Given this list of marker genes MRPS22, WWOX, SLC29A3, GPR101, MEN1, MAP3K1, SYCE1, CDKN1A, MSH4, SNRPN, NR5A1, LEPR (NCBI Gene Id 3953), SNORD115-1, BBS1, CDON, TRAF7, PROKR2, DCC, MKRN3, ARL6, BAP1, PRKAR1A, FGF8, NF2, IL17RD, LHB, TAC3, PWAR1, SRY, USP48, GNRHR, BSCL2 (BSCL2 lipid droplet biogenesis associated, seipin), BMP15, TP63, GDF9, STAG3, PSMC3IP, FGF17, CYP17A1, AKT1, SYCP2L, CAV1, SIM1, KPNA7, PCSK1, LHX4, PIK3CA, SPIDR, HAMP, SEMA3A, DUSP6, HARS2, GLI2, WNT4, HFM1, MCM9, AXL, MSH5, MAGEL2, TFR2, AIP, ROBO1, NPAP1, CDKN1B, PWRN1 (NCBI Gene Id 791114), SPRY4, TKT, OCA2, MSTO1, TERT, DHH, POF1B (NCBI Gene Id 79983), AR, GALT, BMP2, PROK2 (NCBI Gene Id 60675), ZFPM2, CAVIN1, RCBTB1, SMARCB1, DHX37, TACR3, HESX1, FBXO11, SUFU, FSHB, PROP1, NSMF, SOX10, SMO, NHLH2, TWNK, CPE, DIAPH2 (NCBI Gene Id 7989), NDN, NDNF, CYB5A (NCBI Gene Id 1528), HS6ST1, ESR1, EIF2B4, FOS, ATRX, CDKN2C, MOS, GNRH1, MEIOB, AGPAT2, RNF216, NOBOX, PEX1, VAMP7, MCM8, FANCM, PAPSS2, SNORD116-1, ERAL1 (Era like 12S mitochondrial rRNA chaperone 1), NR0B1, BRAF, POU1F1, LARS2, FEZF1, CTDP1, MPV17, SMCHD1, EIF2B2, GPR161 (G protein-coupled receptor 161), KISS1R, SMC3, CISD2, FLRT3, PRORP (NCBI Gene Id 9692), SMARCE1, POR, WRN, CHD7, LEP, BNC1, YARS1, LMNA, CDKN2B, HSD17B4, USP8, FGFR1, TBL1X, SOX3, C14orf39, CYP19A1, PNPLA6, ANTXR1, PEX6, NR3C1, SRA1, CCDC141, HDAC8, GATA4, ERCC6, NIPBL, EIF2B3, OTX2, ESR2, CCDC28B, FOXA2, SOHLH1, EIF2B1, KASH5, BMP6, WNT7A, FIGLA, SEMA3E, NUP107, WT1, ITGA8, FSHR, CLPP, LIG4 (DNA ligase 4), POLG, HSF2BP (NCBI Gene Id 11077), KISS1, PDGFB, GATA3, ZSWIM7, PSMD12, HFE, SOX9, CDH23, WDR11, POLG2, BMPR1B, BPTF, TRMT10A, POLR3H, HERC2, HROB, TP53, PRLR, FOXL2, RAD21, BRD4, ANOS1, TAF6, SMC1A, NIN, HJV, PPARG, here is a description of the gene set: Amenorrhea Absence of menses for an interval of time equivalent to a total of more than (or equal to) 3 previous cycles or 6 months. studied in species Homo sapiens Human Gene Set: HP_AMENORRHEA